The following is a description of a gene set: Reactome Pathway: Localization of the PINCH-ILK-PARVIN complex to focal adhesions This event has been computationally inferred from an event that has been demonstrated in another species.<p>The inference is based on the homology mapping from PANTHER. Briefly, reactions for which all involved PhysicalEntities (in input, output and catalyst) have a mapped orthologue/paralogue (for complexes at least 75% of components must have a mapping) are inferred to the other species. electronically inferred by orthology from the curated human pathway part of: Cell-extracellular matrix interactions species: Mus musculus, and this is the list of marker genes: Pxn, Ilk